Given this list of marker genes Mapk3, here is a description of the gene set: electronically inferred by orthology from the curated human pathway This event has been computationally inferred from an event that has been demonstrated in another species.<p>The inference is based on the homology mapping from PANTHER. Briefly, reactions for which all involved PhysicalEntities (in input, output and catalyst) have a mapped orthologue/paralogue (for complexes at least 75% of components must have a mapping) are inferred to the other species. species: Mus musculus part of: RNA Polymerase I Promoter Clearance Reactome Pathway: RNA Polymerase I Promoter Opening